The following is a description of a gene set: Mouse Gene Set: REACTOME_NEGATIVE_REGULATION_OF_THE_PI3K_AKT_NETWORK Negative regulation of the PI3K/AKT network studied in species Mus musculus, and this is the list of marker genes: Pik3r1, Nrg3, Fyn, Btc, Pik3cd, Ppp2r1a, Irs2, Mapk1, Pdgfra, Tgfa, Klb, Irak1, Lck (lymphocyte protein tyrosine kinase), Ppp2r5a, Hgf, Ereg, Pdgfa, Erbb4, Fgf5, Fgf6, Fgfr1, Fgf23, Hbegf, Fgf17, Fgf20, Cd80, Icos, Pik3cb, Erbb3, Bdnf, Pip5k1a, Esr2, Cd28, Fgf22, Pip5k1b, Ins1, Pik3r5, Fgf1, Rac2, Nrg1, Trib3, Pip4k2c, Pdgfb (platelet derived growth factor, B polypeptide), Il1rap, Ntrk2, Pik3ap1, Ppp2r5c, Akt1, Them4, Cd19, Phlpp2, Fgf7, Akt2, Vav1, Flt3l, Ppp2r5e, Src, Fgf9, Rac1, Fgf8, Ntf5, Pip4k2b, Fgf10, Fgf16, Pik3r6, Il1rl1 (interleukin 1 receptor-like 1), Trat1, Phlpp1, Ptpn11, Areg, Pik3r3, Kitl, Pik3ca, Epgn, Fgf15, Ntf3, Fgfr4, Pten, Pip4k2a, Met, Fgf2, Fgf18, Ppp2r5d, Cd86, Esr1, Ntrk3, Irak4, Ppp2r1b, Ppp2cb, Gab1 (growth factor receptor bound protein 2-associated protein 1), Fgf3, Rhog, Fgfr3, Fgf4, Frs2, Pdgfrb, Ppp2ca, Egfr, Traf6, Myd88, Kit, Mapk3 (mitogen-activated protein kinase 3), Ppp2r5b, Insr, Pik3cg, Erbb2, Akt3, Strn, Pik3r2, Egf, Il33, Grb2 (NCBI Gene Id 14784), Ier3, Pip5k1c, Kl